The following is a description of a gene set: species: Mus musculus Catalysis of the release of ammonia or one of its derivatives, with the formation of a double bond or ring. Enzymes with this activity may catalyze the actual elimination of the ammonia, amine or amide, e.g. CH-CH(-NH-R) = C=CH- + NH2-R. Others, however, catalyze elimination of another component, e.g. water, which is followed by spontaneous reactions that lead to breakage of the C-N bond, e.g. L-serine ammonia-lyase (EC:4.3.1.17), so that the overall reaction is C(-OH)-CH(-NH2) = CH2-CO- + NH3, i.e. an elimination with rearrangement. The sub-subclasses of EC:4.3 are the ammonia-lyases (EC:4.3.1), lyases acting on amides, amidines, etc. (EC:4.3.2), the amine-lyases (EC:4.3.3), and other carbon-nitrogen lyases (EC:4.3.99). Mouse Gene Set: GOMF_CARBON_NITROGEN_LYASE_ACTIVITY, and this is the list of marker genes: Ggct, Pam, Adsl, Ggact, Sds, Sdsl, Chac1, Ftcd, Hal, Chac2, Srr, Asl